Given this list of marker genes Lin52, Lypd1, Ttc7, Mkrn3, Adamts1, Fchsd2, Sema3a, Dapk1, Fbh1, Smad9, Pfkfb3, Ankrd1, Wt1, Ccdc68, Nodal, Vamp1, Fam228b, Cdc42se2, Cenpi, Fech, Rabgap1l, Chrdl1, Nom1, St8sia4, Chek2, Apobec3, Pi15, Cd53, Zc3h4, Cadm1, Zfp781b, Trhde, Nup93, Fut9, Skint7, Clcn2, Ednra, Arl8a, Qtrt2, Rb1cc1, Dkk3, Rnf38, Nup155, Slc5a3, Hoxb3, Runx2, Mpzl1, Gopc, Rbbp5, Alg6, Usp1, Xiap, Klhdc2, Zmat1, Mapk1, Styx, B3galt1, Rreb1, Dip2b, Rab11fip3, Itpr1, Cflar, Tmtc4, Il3, Trim59 (NCBI Gene Id 72558), Wdfy3, Wnt3, Tceanc, Cobll1 (Cobl-like 1), Des, Mllt3, Rgmb, Pias1 (NCBI Gene Id 72966), Gm5114, Arhgef10l, Zfp266 (zinc finger protein 266), Mef2a, Ikbkg, Cysltr1, Cxcl5 (C-X-C motif chemokine ligand 5), Yes1, Tm9sf3, Bche, Sgms1 (sphingomyelin synthase 1), Glrb, Wrnip1, Avl9, Grip1, Ints6l, Spty2d1, Txlnb, Ell2, Eif4ebp1, Tnfaip8, Atosa, Evx2, Cadm2 (cell adhesion molecule 2), Ptprb, Ptpn4, Skint9, Grm5, Epc2, Zswim6, Psma3, Fbxl17, Nectin3, Adgrf5, Dcdc2a, Cldn34c1, Gtpbp2, Slc30a1, Pcsk5, Il1b, 1110059G10Rik, Mtmr12, Smad7, Dlx4, Csn2, Nfyb, Cbln1, Tgfbr3 (NCBI Gene Id 73753), Tbc1d22b, Prkacb, Mthfd1, Cxxc4, Smad1 (SMAD family member 1), Serpinb9g, Slco2b1, Zfp148, Nek1, Rhobtb1, Tbx22, Tle4, Tpm1, Rasef, Zfp407, Sft2d3, Ap1g1, Pmp22, Irf1, Polr3d (polymerase (RNA) III (DNA directed) polypeptide D), Zfand5, Fignl1, Cep135, Rnf214, Vps26a (VPS26 retromer complex component A), Kcne4, Apool, Lrp12, Zfp27 (zinc finger protein 27), Nup35, Morc3, Mex3c, Rsbn1, Dnajb12, Cul3, Golim4, Rerg, Zdhhc21, Ubqln2, Hs3st3b1, Pira12, Slitrk4, Syncrip, Zfp446, Ets1, Gm4884, Rbm41, Pfkfb2, Ddx60, Unk, Msx2, Slc7a2, Igfbp1, Rnf144a, Kbtbd3, Ttll7, Six6, Matcap1, Gje1, Rufy2, Utp18, Pik3r1, Fzd8, Ube2a, Ric1 (NCBI Gene Id 77643), Ssbp2 (single-stranded DNA binding protein 2), Arhgef7, Trdmt1, Camsap2, Crybg3, Dcun1d3, Spred1, Maco1, Ctsc, Zfp521, Nectin4 (NCBI Gene Id 71740), Homer1, Nr2c2, AI182371, Sart3, Aurka, Stard13, Ankrd13c (ankyrin repeat domain 13c), Secisbp2l, Slc7a11, Spag9, Dcun1d4, Aff4, Golt1a, Il21, Bpnt2, Fsd1l, Ms4a4c, Rab39, Calca, Mei4, Cacnb2, Lss, Mfsd2a, Fam8a1, Hopx (HOP homeobox), Tulp4 (NCBI Gene Id 78646), Fhip1b, Fosb, Cacna1g, Tjp2, Tmf1, Gabra1, Rnf138, Irs1, Scn2a, Wdr47, Rev1, Gabra2, Pbrm1, Mtmr6, Tcf12, Atp2b4, Kcns2 (NCBI Gene Id 320005), Xkr6, Herc6, Akap12, Nceh1, Mrc1, A630023A22Rik, Gpatch8, Appl1, Zfp143, Ralgapa1, Gata3, Tet3, Btaf1, Heatr5b, Mdp1, Dnttip2, Hook3, Nr3c2, Rab14, Cdk6, Rmnd5a, Sclt1, Naa20, Golph3, Scamp2, Dach2, Cwc22, Zfp608, Tubgcp5, Necab1, Med14, Cttnbp2, Dck, Akap13, Ptprr, Emc7 (NCBI Gene Id 98979), Car8, Cask, Cnih4, Kif13a, Hnrnpd, Iqschfp, Cd209a, Cfap20, Arhgap35, Ttc38, Grhl3, Vcan, Klf15, Pcf11, Cmtr2, Pter, Zbtb44, Sirt1, Grem2, Vmn1r51, Nxpe3, Sf3a1, Phrf1, Klhl14, Baz2b, Ncam2, Arhgap6, Rbm24, Foxf2, Nck2, Chrna1, Gpm6b, Grk6, Kcnh8, Mex3b, Pafah1b1, Atad1, Arfgef2, Itga2 (integrin alpha 2), Pgm2l1, Vegfa, Zfp874b, Epb41l2, Adamts20, Megf11, Mdm1, Fam76b, Ndrg4, Zfp36l1, Arl6ip6, Tfg, Rnf44 (ring finger protein 44), Mzt1, Asah1, Erich1, Mstn, Topbp1, Gm11992, Smu1, Cdh2, Hace1, Akr1c20, Rgs4, Mrpl39, Ppat, Akain1, Chuk, Fgfr2, Anks1b, Cep126, Gucy1a2, Etaa1, Cxcl16, Setd2, Bmp5, Oas3, Zbtb49, Slc8a1, Kcnma1, Dennd2b, Tmc8, Cnbp, Taok1, Ppm1h, Epha5, Bmpr2, Mkln1, Hectd2, Nfkbia, Car5b, Trpc1, Ccnc, Mbnl1, Ccdc166, Ctdspl2, Zfp689, Trhr, Grsf1, Zmym2, Abcg3, Ash1l, Omg, Sav1, Pum2, Pak2, Reck, Fam118b, Bmper, Sim1, Rai1, Lemd3, Pip4k2c, Wrap73, Phactr2, Mat2b, Phf6, Lrch2, Cdc14a, Slc6a6, Pou2f1, Ino80d (NCBI Gene Id 329170), Sbf2, Ptp4a3, Srsf2, Dync1li2, Camk2d, Cks2, Zfp397, Or52n4, Serpinb9d, Prrx2, Reps2, Sp4, Mkrn2os, Hoxd1, Zfand2a, Usf3, Rad51d, Rbm39, Gabpa, Slc4a7, Vps35, Uty, Tmem196, Aspm, Pdcd10, Tab2, Zfp354c, Hhip, Glis3, Pdik1l, Itgb1, Lrrn1, Cstf3, Iars2, Rtp1, Lin54, Schip1 (NCBI Gene Id 30953), Dleu7, Scoc, Ulk2, Ano4, Dph6, Lix1l, Krt73, Tmem151a, Mast4 (NCBI Gene Id 71635), Mid2, Anln, 1700028K03Rik, Luc7l2, Stxbp5, A830018L16Rik, Pms1, Kcna2, Cdkn2aipnl, Plxna2, Traf3ip1, Kif16b, Extl2, Yaf2, Gtf2h1, Gnaq, Slc38a2 (NCBI Gene Id 67760), Pea15a, Tada1, Dennd4a, Mospd2, Itch, Myt1l, Rif1, Rictor, Carmil1, Cxcl1, Ube3a, Far1, Krit1, Neurod1, Tbc1d24, Lcorl, Plag1, Adra1b, Glipr1l2, Col23a1, Nrf1, Strbp, Dusp10, Qrich1, Ythdc2, Gtf2b, Casz1, Cspp1, Prpf4b, Dst, Spock3, Znrf3, Adgre4, Nhlh1 (NCBI Gene Id 226661), Piezo2, Tob2 (NCBI Gene Id 73089), Rnf111, Cenpc1, Taf4b, Riok3, Gm6377, Frmd6, Epha4, Tafa1, Lrig3, Eml6, Pkd2, Hivep1, Pudp, Nfatc1, Acsl4, Crebrf, Zc2hc1a, Rcn2, Dbx1, Phactr4, Otud6b, Sorcs3, Mpc1, Lamtor3, Fgf4, Rock2 (Rho-associated coiled-coil containing protein kinase 2), Orc1, Dlg2, Kdm6a, Zc3h12c, Ppp1r9b, Tnrc6c, Rps6ka3, Tnfrsf11b (tumor necrosis factor receptor superfamily, member 11b (osteoprotegerin)), Tagln2, Dmxl1, Filip1l, Tmprss5, Rad21, Slc1a1, Psd3, Jph1, Il1rap, Hnrnpa3, Lrrc42, Gm5592, Mfhas1, Sumf2, Zbtb10, Abi1, Loxl3, Wiz, Lrp8, Svil, Spry1, Fbxo33, Mis18a, Zbtb2, Hnrnpll, Snx27, Prr12, Tlr3, Necap1, Mbd2, Lats1, Neurod6, Kif23, Pax9, Mcu, Ier3, Usp6nl, Zfp592, Irf2bpl, Epb41l1, Diaph2, Cyth3, Gfod1, Rc3h2, Fgd4, Lhx8, Shoc2, Fgf12, Fgl2, Matn2, Ctdsp1, Prkcd, Ddx10, Lifr, Rusc2, B3galt2, Satb2, Slc12a6, Zmym5, Slc18a2, Slc5a8, Osbpl8, Akap7, Marchf6, Ccdc169, Timm8a1, Sema4b, Carf, Tshz3, Wdr43, Arap2, Pik3c2a, Gucy1b1, here is a description of the gene set: from publication Chen Y, Wang X (PMID 31504780) Genes predicted to be targets of miRBase v22 microRNA mmu_miR_669d_3p in miRDB v6.0 with MirTarget v4 prediction scores > 80 (high confidence targets). Mouse Gene Set: MIR_669D_3P species: Mus musculus